The following is a description of a gene set: species: Mus musculus A zone of apposition between the membranes of an organelle with another membrane, either another membrane of the same organelle, a membrane of another organelle, or the plasma membrane. Membrane contact sites (MCSs) are structured by bridging complexes. They are specialized for communication, including the efficient traffic of small molecules such as Ca2+ ions and lipids, as well as enzyme-substrate interactions. Mouse Gene Set: GOCC_ORGANELLE_MEMBRANE_CONTACT_SITE, and this is the list of marker genes: Atg14, Osbpl5, Fate1, Rab38, Saraf, Stx17, Acsl4, Bltp1, Gramd1c, Clcc1, Rab32, Atad3a, Tmx2, Atg16l1, Atg5, Gramd2a, Sacm1l, Micos13, Atg2a, Tomm40, Ckmt1, Stard3, Rmdn3, Gramd1a, Gramd1b, Bltp2, Osbpl1a, Tmcc1, Ahcyl1, Clstn3, Stard3nl, Esyt2, Pdzd8, Bcap31, Vps13a, Stimate, Selenon, Tmx1, C2cd2l, Zfyve1, Mospd2, Tomm20, Serac1, Micu1, Tmem41b, Bcl2l10, Pik3r4, Mboat7 (membrane bound O-acyltransferase domain containing 7), Esyt3, Canx